Given this list of marker genes FAM8A1, RNF182, MCUR1, RNF144B, SIRT5, DEK, RBM24, MBOAT1, GFOD1, CD83, CAP2, ID4, TBC1D7, TPMT, NOL7, KDM1B, NHLRC1, PHACTR1, KIF13A, RANBP9, NUP153, here is a description of the gene set: from publication Nikolsky Y, Sviridov E, Yao J, Dosymbekov D, Ustyansky V, Kaznacheev V, Dezso Z, Mulvey L, Macconaill LE, Winckler W, Serebryiskaya T, Nikolskaya T, Polyak K (PMID 19010930) Human Gene Set: NIKOLSKY_BREAST_CANCER_6P24_P22_AMPLICON Genes within amplicon 6p24-p22 identified in a copy number alterations study of 191 breast tumor samples. species: Homo sapiens A single cancer cell contains large numbers of genetic alterations that in combination create the malignant phenotype. However, whether amplified and mutated genes form functional and physical interaction networks that could explain the selection for cells with combined alterations is unknown. To investigate this issue, we characterized copy number alterations in 191 breast tumors using dense single nucleotide polymorphism arrays and identified genes with copy number gain organized into 30 amplicons. Amplicons were distributed unequally throughout the genome. Each amplicon had distinct enrichment pattern in pathways, networks, and molecular functions, but genes within individual amplicons did not form coherent functional units. Genes in amplicons included all major tumorigenic pathways and were highly enriched in breast cancer-causative genes. In contrast, genes with somatic mutations in breast cancer were distributed randomly over the genome, did not represent a functionally cohesive gene set, and were relatively less enriched in breast cancer marker genes. Mutated and gained genes did not show statistically significant overlap but were highly synergistic in populating key tumorigenic pathways including transforming growth factor beta, WNT, fibroblast growth factor, and PIP3 signaling. In general, mutated genes were more frequently upstream of gained genes in transcription regulation signaling than vice versa, suggesting that mutated genes are mainly regulators, whereas gained genes are mostly regulated. ESR1 was the major transcription factor regulating amplified but not mutated genes. Our results support the hypothesis that multiple genetic events, including copy number gains and somatic mutations, are necessary for establishing the malignant cell phenotype.